Given this list of marker genes RELB, ATF4, IL1B, IL10, CREB5, MAPK11, IL6, RELA, CREB3L1, MAPK14 (mitogen-activated protein kinase 14), NFKB2, NFKB1, MAPK13, MAPK12, CREB3L2, CCL2, CD14, CREB3L3, CREB3L4, CREB1, TLR4, CREB3, REL, here is a description of the gene set: LDL- influence on CD14 and TLR4 Human Gene Set: WP_LDL_INFLUENCE_ON_CD14_AND_TLR4 species: Homo sapiens